Given this list of marker genes ADM, RASSF3, TMCC1, UBR3, SYT10, PGRMC2, DAPK1, MAP3K7, PCNX1, THUMPD3, RHD, SHANK2, SV2C, HMGA2, ADAM19, TENT2, MTM1, SNX20 (NCBI Gene Id 124460), ATP1A2, ADRA1A, GPR52, NUDT11, CDK8, PGM2, ZNF235, MAB21L1, CTTNBP2NL, RPS6KA6, BLOC1S2, GNA13, PTPRD, CIPC, ASPN, MCL1, BAK1, TMEM265, CTH, REEP3, THAP2, COL19A1, NAP1L5, HOXA9, PFDN4, EIF2S1, TM2D3, SLC16A6, FAM136A, ZDHHC6, SMAD1, TMEM68, CPPED1, PLEKHH1, EPC2, RB1, BAG4, ARB2A, GMFB, RSPRY1, VDAC1, RCN2, ATM, BID, ZNF608, PHAF1, KPNA2, TNRC6B (NCBI Gene Id 23112), FBXL19, UBN2, FLVCR1, PIM1, RBM24, ZFHX4, LSM11, UGT8, PAWR, PALM3, ZNF462, RNF6 (NCBI Gene Id 6049), PPP1R15B, MRAS, SUZ12, MARK1, ADAMTS19, ZNF469, CREBRF, PRKCD, ATF2, RLF, NUS1, CAMSAP1 (NCBI Gene Id 55490), CDC6, TTC13, PHLDB2, SSX2IP, E2F7, GABRB2, UCK2, SLC5A1, MDN1, CILP, STK39, HSPA8, CHD1 (NCBI Gene Id 1105), ACADM, POLH, B4GALT4, USP3, JARID2, PAK2, SLC4A4, FGD1, MAP2, CCDC82, LMLN (leishmanolysin like peptidase), PLEKHG1, CNTNAP3B, SACS, PITPNC1, POLR3G, ERC2, RCN1, TBC1D4 (TBC1 domain family member 4), NABP1, NAA15, MTX2, TNPO1, MAPK6, CDK2AP1, RHOU, ABCC4, PTEN, CACNB2, SSH2, GABRA4, INHBB, TMEM106B, HGF, EP400 (E1A binding protein p400), TTPAL, FHIP1A, PRKCQ, RDH14, BAZ2B, ADAM23, PEX13, RCOR1, SPDYE5, MIER1, ARHGAP21, ABL2, SLC2A13, DCDC2, UBE2H, CELSR1, SLC35E4, NEK1, MAT2A, REST, NAGPA, OTUD4, ARL6IP6 (NCBI Gene Id 151188), CDK6, SLC25A16, NUP50, TOB1, TGIF2-RAB5IF, ITGB8, ALS2, MTTP, OSBPL11, MTDH, ZCCHC24, ACBD5, CASZ1, ANKRD28, PLOD2, TET1, TAOK1, KIAA2013, PIK3R3 (NCBI Gene Id 8503), RBM20, MSMO1, CXADR, ATP11C, SH3PXD2A, ULK1, HAS3, ERLIN1, ZDHHC20 (NCBI Gene Id 353177), LSM12, SLC19A2, PELI2, TRANK1, TANC2, PDHX, FAM199X, KCNJ2, FAM98A, SEMA6D, DDX17, FBXO28, PCDH9, ZIC5, UBE2G1, SLC22A23, TMC7, SLC24A4, AKAP7, RAB5IF, PPP4R1, ZNF516, RPGR, ZNF410, PHTF2 (NCBI Gene Id 57832), CD200, MMP16, ZNF598, WNK3, TRPC3, CHORDC1, ALDH5A1, CCDC28A, NAB1, STRADB, EZH2, SULF1, TOP1, ZFC3H1, AMOT, BOD1, ABHD5, ZSWIM6, MAEA, CTSV, DNA2, HTR1B, USP15, G3BP2, PLP1, NLK, CNTNAP3, YPEL1, UBE4B, ATAD1 (ATPase family AAA domain containing 1), SRGAP1, SEPTIN10, GPALPP1, PHF6, ARPP19, SLC36A4, CHSY1, ZBTB18 (zinc finger and BTB domain containing 18), CLASP2, DGKH, BBX, RAP2C (RAP2C, member of RAS oncogene family), ACVR1C, EIF5, SFXN1, ZDHHC18, B3GNT5, EIF4G2, SENP5 (NCBI Gene Id 205564), RAB21, LEF1, SH3RF1, SCAMP1, TMEM260 (transmembrane protein 260), PECAM1, ANKS1A, PPP3R1, ANKRD63, EPC1 (NCBI Gene Id 80314), PARP14, LTBP1 (NCBI Gene Id 4052), FGF18, MCUR1, FBXO11, MTFMT, PHF20L1, FANCF, OVOL2, PCDH18, IQCJ, ATPAF1, SRCAP, EP300, ARMCX2, KBTBD8, MAP7, CREB1, MFSD14A, NATD1, ETNK1, DENND1B, USP25, CACNA1C, CHFR, ESR1 (estrogen receptor 1), ARFGEF1, BBS7, SLC7A11, STXBP5, ARL5B, TAF9B, ICE1, CELF2, CTXN3, DOCK4, ST6GAL2, SLC1A1, RNF141, CPSF2, TNRC6C (NCBI Gene Id 57690), SLC33A1, RESF1, ART3, BCR, RGS4, FRAT2, RYK, PALS2, SLC45A4, BFAR, ADAM9, EPB41L3, KLHL42, RFK, TWF1, VANGL2, FA2H, CCDC6, NIPAL2, LIMS1, CCNJ, DUSP5, SKP2, LNX2, ANKS1B, SLC25A36 (NCBI Gene Id 55186, solute carrier family 25 member 36), PRR5L, MATR3, ADAMTS6, YAF2, PFKFB3, RCBTB1, LOXL2, DMRT3, ACSL3, NCOA4, SBNO1, PAN3, G2E3, CRADD, SERBP1, HOXC4, NCEH1, HOXD13, KPNA6, STYX, BEND4, NHS, COL1A2, ARK2N, COL10A1, NT5C1B-RDH14, WNK1, SRP19, PSD3, DLG5, PARPBP, SNN, SOCS7, LIN28B, USP37, TMEM184B, PLCB1, KLHL18, HEPHL1, BHLHE40, TMEM86A, CHAC1, GRHL3, SRSF6, PPP3CB, RTF1, PFKFB2, FRMD4B, GMDS, GSK3B (glycogen synthase kinase 3 beta), HOXA5, TTPA, MAN2A1, PHF14, SLC38A2, TBC1D15, CEP350, TNRC6A, MXI1, TRIM65, STRBP, MICAL3, PHF3, JAG1, IL18R1, CREBZF, LRRC2, USP9X, TP53INP1, TET3, FPGT, DMXL1, PTGS2, RHOQ, TRIB2, ITGA6, TET2, ADAM17, HMGA1, ULK2, CTNND2, TMEM248, PHF21A, SFPQ, LARP1, BRWD1, here is a description of the gene set: from publication Chen Y, Wang X (PMID 31504780) Human Gene Set: MIR4465 Genes predicted to be targets of miRBase v22 microRNA hsa-miR-4465 in miRDB v6.0 with MirTarget v4 prediction scores > 80 (high confidence targets). studied in species Homo sapiens